The following is a description of a gene set: Catalysis of the reaction: (S)-3-hydroxyacyl-CoA + NAD+ = 3-oxoacyl-CoA + NADH + H+. Human Gene Set: GOMF_3_HYDROXYACYL_COA_DEHYDROGENASE_ACTIVITY studied in species Homo sapiens, and this is the list of marker genes: HSD17B10, HSD17B4, HADHB, HADH, HADHA, EHHADH